The following is a description of a gene set: studied in species Homo sapiens from publication Chen Y, Wang X (PMID 31504780) Human Gene Set: MIR4633_5P Genes predicted to be targets of miRBase v22 microRNA hsa-miR-4633-5p in miRDB v6.0 with MirTarget v4 prediction scores > 80 (high confidence targets)., and this is the list of marker genes: CDH13, SESTD1, ZYG11B (NCBI Gene Id 79699), FLRT3, IGF1, PRP4K, CIBAR1, ADSS2, CCNG1, BICDL1, ADAM22, HELZ, AKAP10, AK7, SOCS2, SEPTIN14, ZNF85, GSAP, GEN1, CENPK, THRAP3, RSBN1, PITPNC1, CAPZB, WIPF3, NR5A2, UCHL5, ARMC8, CEP44, HLF, PYURF, NRIP1, PDZD11, TMEM170B, SUCLG2, XRCC5, PDS5B, MRS2, TAB3, FAM47E, NRCAM, CPLANE1, VPS37A, PYROXD1, SLC38A2, ERCC6L (NCBI Gene Id 54821)